The following is a description of a gene set: from publication Shin DM, Shaffer DJ, Wang H, Roopenian DC, Morse HC 3rd (PMID 19010892) Human Gene Set: SHIN_B_CELL_LYMPHOMA_CLUSTER_3 Aside from Myc-activating translocations characteristic of plasmacytomas (PCT), little is known about genetic factors and signaling pathways responsible for the development of spontaneous B-cell lineage lymphomas of mice. Here, we characterized the transcriptional profiles of PCT, centroblastic diffuse large B-cell lymphomas (CBL), and high-grade splenic marginal zone B-cell lymphoma (MZL++) using high-throughput quantitative reverse transcription-PCR. Expression profiles of CBL and MZL++ were strikingly similar and quite unlike that of PCT. Among the genes expressed at significantly higher levels by PCT were a number involved in NOTCH signaling, a finding supported by gene set enrichment analyses of microarray data. To investigate the importance of this pathway, NOTCH signaling was blocked in PCT cell lines by treatment with a gamma-secretase inhibitor (GSI) or transduction of a dominant-negative mutant of MAML1. These treatments resulted in reduced expression of NOTCH transcriptional targets in association with impaired proliferation and increased apoptosis. GSI treatment of transformed plasma cells in a primary PCT also induced apoptosis. These results integrate NOTCH activation with oncogenic signaling pathways downstream of translocated Myc in the pathogenesis of mouse PCT, two signaling pathways also implicated in development of human multiple myeloma and T-cell lymphoblastic lymphoma. studied in species Mus musculus Cluster 3 of genes distinguishing among different B lymphocyte neoplasms., and this is the list of marker genes: WNT5A, LTB, CBX5, CXCR6, CD86, FZD1, BCL2, FGR, IL2, LFNG, NFKB1, TNFSF13, TGFB1, CCND3, LCK, NFATC1, ZEB2, CXCL13, JAK2, CADM1, IRAG2, NFKB2, TNFRSF1A, IL18, CCND1, HHEX, MAF, ID2